Given this list of marker genes CADM1, NECTIN2, NECTIN4, NECTIN3, CADM3, NECTIN1, PVR, here is a description of the gene set: Human Gene Set: REACTOME_NECTIN_NECL_TRANS_HETERODIMERIZATION Nectin/Necl trans heterodimerization studied in species Homo sapiens